The following is a description of a gene set: Human Gene Set: MIR3121_5P from publication Chen Y, Wang X (PMID 31504780) studied in species Homo sapiens Genes predicted to be targets of miRBase v22 microRNA hsa-miR-3121-5p in miRDB v6.0 with MirTarget v4 prediction scores > 80 (high confidence targets)., and this is the list of marker genes: ZBTB14, TMEM14B, SH3TC2, SLC7A14, TIMM8B, PRPF40A, TCEAL7, NRXN1, FAF2, UBXN10, C1orf21, C14orf132, GATA3, BCL6, PHF6 (NCBI Gene Id 84438), TLR3, RNF112, PELI1, ZNF728, PAX9, MGST1, AMIGO2, EPB41L1, ZBTB1, NDUFA10, YIPF2, KCNMA1, GPN2, DIP2C, PITPNC1, SEPHS1, ZNF407, DSG2, TMEM97, C1RL, LPGAT1, GABRA4, CBFA2T3, GOLT1B, GRIK3, CLASP1, BTLA, TRAM1L1, MTHFD2, WRNIP1, RAB30, LRP8, CNTN3, ADARB1, GSKIP (GSK3B interacting protein), PCLO, CADM2, PPP3CB, TMEM86A, POU2F1, FGF12, RILPL2, SLC6A8, B3GALT2, KAT6B, CTSC (cathepsin C), SEMA6D, SLC35B3, ARHGEF3, ANKRD16 (NCBI Gene Id 54522), SEMA4G, ATP6V1C1, SPAG9, DAG1, PMPCB, LZIC, CD160, TENM3, ENPP5, CSNK1G1, GPM6B, CYP4F22, CDON, UBAP1, CDK8, PRICKLE2, IPCEF1, ELFN1, TAF1, SYNC, NR3C2, ADAMTS8, FAM168B, NLRP4, ADAM20, PLCB1 (NCBI Gene Id 23236), STIM2, TAOK1, HAPSTR1, BMPR1B (bone morphogenetic protein receptor type 1B), NUFIP2, CD93 (CD93 molecule), OSBP, ABCA12, TMPRSS11D, FAM53C, TMEM276-ZFTRAF1, FRZB, TRIM22